Given this list of marker genes MED1, TLE4, ZNF703, DNAJA3, ATF4, TACC2, STAT5A, SP100, ATF2, IKZF4, TRIM32, KAT6A, ESRRB, TCF7L2, DDX54 (NCBI Gene Id 79039, DEAD-box helicase 54), FOXA2, CARM1, KAT5, TP53BP2, NCOA7, TBX2, TAF12 (NCBI Gene Id 6883), ASCL1, COMMD7, DDIT3, PITX2, KLF4, PBX2, NR1H2, PADI2, GTF2A2, FOXH1, CCDC62, PPARG (NCBI Gene Id 5468), TAF11, CENPF, MLX, PKN1, LMO1, LATS1, GSC, HMGB1, SIN3A, MYOCD, HIRA, SOX9, GTF2H1, GATA3, TFDP1, CSNK2B, CEBPG, MAGEA2B, TPT1, H2BC9, CREBBP, NFKBIA, KAT2B, HMGA1, UHRF2, PAGR1, ZNHIT3, CRTC1, SMAD3, SMARCA1, GSK3B (glycogen synthase kinase 3 beta), TLE1, HHEX, CRY1, EEF1D (NCBI Gene Id 87167), AHR, SIRT1, GATA4, TAF7, BBS4, SRI, BAZ2A, PASD1, CTDP1, STAT3, BCL2, KDM3A, SYVN1, STK4, HMGB2, NR1I2, DDX5, GTF2B, NR1H4, TWIST1 (twist family bHLH transcription factor 1), BCL10, BBS1, HDAC9, TBK1, FBP1, TAF4, NPM1, USF1, ACTB, CIITA, TCF23, RPS3, CREB3 (cAMP responsive element binding protein 3), NKX2-5, RAD23B, POU1F1, HSPB1, NBN, FHL2, SETD3, MAVS, DCAF1, LRIF1, ZBTB7A, DMAP1, EP300, MTDH, GATA2, NCOA1, PRKCB, RB1, DOT1L (DOT1 like histone lysine methyltransferase), HAND2, TRIP4, MEF2D, HMGN3, SOX17, ZNF516, MED30, NKX6-1, RFC1, NLRP3, DNAJA1, PARP10, CREB1, RUNX1T1, CEBPB, TP53BP1, ISL1, BBS2, WBP2, SMARCB1, PTPN2, HDAC3, BBS5, RNF14, JUN, FOXC1, SNW1, EPAS1, LMO4, CREM, CNOT7, HDAC4, PCNA, SOST, XPO1, TP53, GRHL1, KAT8, ARNT2, NIF3L1, CTBP1 (C-terminal binding protein 1), SRARP, PITX1, HDAC1, ARID5A, HNF4A, ASCL2, LMO2, ID4, RARB, COMMD8, NHLH2, MYOD1, PRDM13, MAPK3, HOXA7, FKBP4, JUND (NCBI Gene Id 3727), PRMT2, NCOR2, MEF2A, RARG, GTF2I, LDB1, ETS1, PROX1, HDAC7, HIF1AN, EBF4, GTF2A1, PHB2, BCAS3, HOXC13, UBXN7, ESR1, CNOT1, YWHAZ, BCOR, KDM4C, PDCD11, PPARD, BHLHE41, GATA1, NFIA, XPC, SOX10, KDM1A, PRDM16, TRERF1, FOXP3, PARP1, CALR, HEY2, GMNN, PSMC5, NUCKS1, PPARGC1A (NCBI Gene Id 10891), MED24, TRIP6, LMO3, RBBP8, PIAS1, CRX, IRX5, RERG, DAZAP2, DTX3L, EN2, TRIM24, PSIP1, SRF, PSMD10, BBS7, CRKL, SPI1, BCL6, PURB, CD34, SMARCA4, FOXP1, CBX5, RXRA, SRY, ANKRD42, POU4F1, MED16, BRD8, RBPJ, POU5F1, CEBPA, DUSP26, YY1, MLXIPL, TRIB1, AKAP8, MED13, AR, HES6, NR0B1, BBS10, DACT1, GABARAPL1, TOB2, CCNT1, TAF9, VDR, WFS1, ANXA4, ADD1, NFYB (nuclear transcription factor Y subunit beta), MAGEA2, TACC1, SMARCE1, SMAD4, CTNNB1, NOTCH2, MIXL1, ASAH1, NRIP1, ARID1A, PBX1, ZNF366, TP73, MDFIC, TTC8, FLT3, MMS19, NEK6, SCX, PRAME, JUP, TMF1, STING1 (NCBI Gene Id 340061), CDKN2A, ATOH8, USF2, MKKS, CXXC5, CRTC2, DCAF13, SETD6, COMMD6, CPNE1, MED25, FAM220A, STRN, NCAPG2 (non-SMC condensin II complex subunit G2), FLNA (NCBI Gene Id 8272), PPARGC1B, TBX3, MED12, SETD1A, PIAS2, TRIB2, DDX20, CITED2, HDAC11, BHLHE40, SP3, TDG, ZNF653, PBXIP1, JMJD1C (NCBI Gene Id 9323), SOX8, LHX3, WIPI1, SIK1 (salt inducible kinase 1), BCL11A, LEF1, TCF21 (transcription factor 21), TBXT, KAT2A, TXLNG, FOXL2, CTBP2, NSD1, SDR16C5, NKX3-1, TFDP3, MED14, GBX2, ZBTB8A, HDAC5, BUD31, TAF1, CDK5RAP3, ANKRD2, ANKRD1, HSF1, TBP, KLF5, HEY1, OASL, NFE4, PURA, NLK (nemo like kinase), MYC, STAT5B (NCBI Gene Id 6777), PTPRT, YAP1, FOXO4, MED17, MAPK14 (mitogen-activated protein kinase 14), HDAC2, TRIM68, GRHL2, CHCHD2, TRIP12, GFI1B, ZBTB17, ARNT, HCLS1, NCOA3, MEF2C, DAXX, ZFPM2, TAF6, ELK1, DNAAF4, TAL1, NCOA2, PARP9, NCOA6, MAX, RBFOX2, MAP3K7, TCF3, HDAC8, FIZ1, PER1, THRAP3, FIGLA, RUNX2, EIF4E, RELA, NOC2L, DHX9, IFI27, PPID, DNMT3A, EOMES, TCERG1, NFATC1 (NCBI Gene Id 4772), METTL23, SLC30A9, SMARCD3, ZMYND8, RNF6, C1D, MED4, NR4A1, ID3, TBX6, KDM5D, TBX5, MAP3K10, PARK7, MAD2L2, HMGA2, ID2, TCF12, HAND1, LYAR, EGR2 (NCBI Gene Id 1959), AIP (aryl hydrocarbon receptor interacting protein), ZFPM1, DAPK3, E4F1, PSMA6, RAD21, PSMD9, PRRX1 (NCBI Gene Id 5396), DHX33, TAF10, ETS2, NCOR1, TEAD3, NR4A3, CRY2, TRIM6, SP1, LCOR, TCP10L, ACTN4, BMAL1, DGKQ, EXOSC9, CHD4, SIRT2, PTMA, NR4A2, PRKDC, CRTC3, RUNX1, ASXL1, BRMS1, TADA3, MTA1, REST, MTA2, TBX20 (NCBI Gene Id 57057), XBP1, ZBTB49, NEUROD1, FAM220BP, FAF1, YWHAH, PRDM5, GATA6, PDX1, CGGBP1, TGFB1I1, SMAD2, NFE2L2, SPEN, FOS, TCF15 (transcription factor 15), RBX1, PPARA, E2F1, NAAA, HCFC1, BCL3, HIPK2, VHL, RNF25, DLL1, INTS13, HES1, WWP2, TAF4B, SKI, HIF1A, NR0B2, NKX2-1, KEAP1, here is a description of the gene set: species: Homo sapiens Binding to a DNA-binding transcription factor, a protein that interacts with a specific DNA sequence (sometimes referred to as a motif) within the regulatory region of a gene to modulate transcription. Human Gene Set: GOMF_DNA_BINDING_TRANSCRIPTION_FACTOR_BINDING